The following is a description of a gene set: Human Gene Set: WP_MAPK_AND_NFKB_SIGNALING_INHIBITED_BY_YERSINIA_YOPJ MAPK and NFkB signaling inhibited by Yersinia YopJ species: Homo sapiens, and this is the list of marker genes: IKBKG, RAF1, CHUK, MAPK1, IKBKB, RRAS, TRAF6, NFKB1, MAP3K1, MAP2K6, NFKBIA, MAP3K14